Given this list of marker genes ATPAF2, CPSF3 (cleavage and polyadenylation specific factor 3), FRRS1L, EIF2AK1, PEX10, RNU4-2, SYNE1, CYB5A, POMGNT1, SCYL1, CLP1, NSD1, AQP4, MED23, CCDC88C, PSAP, CTNNB1, PTPN23, HECTD4, SAMHD1, YIF1B, H3-3A, FBXO7, GJA1, RNASEH2A, FKBP6, ERCC1, TMTC3, DAO, SLC16A2, MARS1, STN1, MPLKIP, SPTBN2, UNC80, SUCLA2, KCNB1, ARF1, COL4A2, PEX6, MYO5A, TSEN15, IFT56, LIAS, ATL1, IBA57, ERCC8, GAS1, PEX2, ASNS, EIF2S3, GTF2H5, TSEN2, AFG2A, HTRA1, TUBB3 (tubulin beta 3 class III), HMBS, DLD, MT-TF, EIF2B2, RPS6KA3, WASHC5, CTNNA2, PPFIBP1, EIF4A2, PRRT2, CLPB, UBTF, ZFYVE26, MED13L, GLE1, GFAP, SIX6, CRIPTO, ASCC3 (activating signal cointegrator 1 complex subunit 3), RLIM, GRIA4, SCN2A, GNAO1, ESAM, GRIN1, TEFM, LRRK2, NAGA (NCBI Gene Id 4668), NSRP1, REEP2, GLYCTK, CKAP2L, TPI1, PON2, SPR, REEP1, DARS2, NDUFA13, PCYT2, MT-ATP8, NEUROD2, MRPS22, RANBP2, PAFAH1B1, ZBTB11, DHPS, SATB1, SLC30A10, WDR45B, PRNP, ERCC2, ATP13A2, GBA2, MCCC2, TAF15 (NCBI Gene Id 8148), SDCCAG8, STAG2, TRAK1, YWHAG, IFT172, MRAP, WARS2, ERCC4, KIF1C, BBS7, RAB18, SDHD, ANKLE2, ATP1A2, PFN1, FOXH1, WLS, CAMLG, DNMT1, GRM7, PEX14, PNP, AASS, KCNJ6, VPS41, HIKESHI (heat shock protein nuclear import factor hikeshi), GBA1, LINGO1, ATXN7, NTRK2, GAMT, ABHD12, KLC2, DNAJC30, SLC39A14, SCYL2, GSX2, GABRA5, GAN, RAB3GAP2, ATXN2, AP4S1, MATR3, GLB1, PLAA, COL4A1, XPA, ATP7A, MED17, ISCA2, GM2A, TIMM50, ALS2, MINPP1, KCNA2, KDM5C, GJB1, GLRA1, NODAL, RERE, RAB3GAP1, NCF1, SCN4A, VAPB, ATP6V1E1, AP4B1, DPH5, SPAST, LIPT1, AARS2, STXBP1, ATP6V1A, NHLRC1, MED27 (mediator complex subunit 27), AP4E1, SUZ12, ATXN8OS, PLAAT3, MORC2, PNKP, DDHD1 (NCBI Gene Id 80821), OPHN1 (oligophrenin 1), TFG, TMEM63C, PRPS1, SHH, UGDH (NCBI Gene Id 7358), ATP5F1D, LONP1, COQ5, PHGDH, CEP19, PNPLA6, AMACR, WDR45, RUSC2, HSD17B10, EDNRB (endothelin receptor type B), EIF4H, SPTBN1, PON3, BAZ1B, ERBB4, PEX26, DSTYK, COG2, EML1, SDHB, MT-ND4, KIF2A, SV2A, SLC12A6, PRKN (parkin RBR E3 ubiquitin protein ligase), POLR1A, FOXP1, PARK7, STUB1, FBXO28, GTPBP2, MT-ND3, PRPH, TTI1, TREX1 (NCBI Gene Id 82474), MFSD2A, PIGA, BBS9, PPT1, MOCS2, GCDH, ENSG00000288330, RNASEH2B, TRMT10A, RFT1 (NCBI Gene Id 91869), CYP27A1, LYRM7, TSEN34, BBIP1, HEXB, ELOVL4, MTPAP, DDB2, TRAPPC4, CLTC, MARS2, POLR1C, KIF5C, KANK1, SCN3A, GAD1, ERLIN1, ZSWIM6, AARS1, KCNA4, NDUFV2, RFXANK, CACNA1B, SPG7, SYNGAP1, RAB11B, KIF11, HCN1, ATP5F1A, GRIN2D, NDUFA2, ACAT1, GFM1, EPM2A, MED12 (mediator complex subunit 12), NAA10, HEPACAM, UBE4A, ZIC2, NR2F1, ATP6V0A2, MECR, NDE1, KCNC3, RNASET2, TDP1, SLC6A8, ATN1, ECHS1, GTF2E2, CYFIP2, KPNA3, PSEN1, TBP, GLRX5, SCLT1, EZH2, CEP85L, TRAPPC12, SLC32A1, CDC40, DRG1, UBAP1, TBCD, SLC25A22, NUS1, ANXA11, NEFH, RNF170, ABCC8, ATXN10, PSMC1, PEX16, WDPCP, GABRB2, WARS1, DHCR24, ABCD1, SLC12A2, LMNB1, TNR, NOTCH3 (notch receptor 3), MT-TW, SNORD118, ABCA12, NEFL, AFG3L2, PEX1, NALCN, CHMP1A, INPP5K, XPC, AFG2B, TCF20, ACBD6, ACTL6B, VRK1, NFU1, SLC1A4, GJC2, DNM1L, TMEM222, BUD23, CCT5, CEP290, RTTN, INTS8, GRM1, PI4K2A, NDUFV1, PQBP1, RAD50, MTHFR, MAG, STX1A, CPT1C, CLCN4, FTH1, TUBGCP2, DYM (NCBI Gene Id 54808), MTO1, ASPA, SPG11, DCTN1, ODC1, PRDM8, SCAPER, PEX12, ADAR, EXTL3, PRDM13, OSTM1, OSGEP, TIMM8A, KIF1A, FOXG1, DTYMK, ELN, NACC1, WDR4, GRIN2B, NADK2, REPS1, ZNF335, DPM1, ARSI, CIT (NCBI Gene Id 11113), ATAD1, ENTPD1, ADGRG1, CACNA1D, DCX, TCEAL1, TMEM270, MCOLN1, AMFR, NKX6-2, SDHA, RNU7-1, SETX, PTCH1, TPK1, FLNA, MKKS, NUBPL, POLR3B, OTUD6B, CAMK2B, GOT2, KCNT1, OPA1, ERCC3, L1CAM, SHQ1, LIPT2, CTC1, UBQLN2 (NCBI Gene Id 29978), EXOSC5, BCS1L, GCH1 (NCBI Gene Id 93984), MCCC1, NPC1, TANGO2, PNPT1, PIGN, KARS1, GLI2, DISP1, LZTFL1, SQSTM1, SPTAN1, IFT27, TRMT5, SOX2, ADAT3, ATP6AP2, ATXN1, CNKSR2, PIGP, CYB5R3, HACE1, PARS2, ARSA, SPG21, CACNA1G (calcium voltage-gated channel subunit alpha1 G), POLG, SZT2, C2orf69, MICOS13, AUTS2, TMX2, CRLF1, ZNF668 (zinc finger protein 668), MSL3, BEAN1, KMT2B, FDX2 (NCBI Gene Id 2143), SNCA, PPP3CA, DDX3X, RNASEH2C, TELO2, LIMK1, GATAD2B, MAN2B1, GDAP2, PGAP1, NTNG2, PEX13, TSPOAP1, GFM2, KRAS, NPHP1, MT-ND1, TXN2, TBCE, PPIL1 (peptidylprolyl isomerase like 1), NIPA1, STAMBP, SRD5A3, LYST, TMEM67 (NCBI Gene Id 91147), COPB1, GRIA3, MT-ND6 (mitochondrially encoded NADH:ubiquinone oxidoreductase core subunit 6), ABHD16A, IREB2, COX15, BBS10, NEXMIF, TYROBP, AFF3, ANK3, SLC19A3, MOCS1, WDR48, MFN2, CFAP418, ATP5MK, ISCA1, AGTPBP1, SETBP1, RNU4ATAC, SMPD1, RFC2, TECPR2, IFT74, UNC13A, CLIC2, HPDL (NCBI Gene Id 84842), PLP1, FTL, HTRA2, CNOT1, PCDH12, ARG1, ADARB1, VPS50, AIFM1, AMPD2, CAMK2A, GBE1, EXOSC8, WWOX, MRPS34, TUBB4A, PEX3, BICD2, TCTN2, CELF2, FGF8, IRF2BPL, NAXD, CASP2, GEMIN4, KY, APC2, MED25, ALG11, PODXL, TAF4, BCKDHB, SELENOI, CSF1R, SACS, PAX3, TAF1, CDKL5, UBA5, BBS5, ACTB, SLC18A2, BCAS3, GABRA2, MT-ND2, FAR1, TTC19, ERCC6, TREM2, PON1, COQ4, MT-TV, GABBR2, NTNG1, PEX5, SNX14, KATNB1, SERAC1, FUS, CACNA1C, DLL1, CNTNAP2, LAGE3 (L antigen family member 3), SIK1 (NCBI Gene Id 54018), SVBP, TARS1, GUF1, LETM1 (leucine zipper and EF-hand containing transmembrane protein 1), CFAP410, NUP62, ARL6, MAPT, VPS4A, SUMF1, SCN1A, GPAA1, AUH, PEX7, HSPD1, MT-TL1, TP53RK, FIG4 (FIG4 phosphoinositide 5-phosphatase), CHP1, ARL6IP1, ZNF592, COASY, DNAJC19, MCEE, DMXL2, VCP, SDHAF1, AP1G1, SIX3, TBK1, UFM1, CARS1, GTF2IRD2, EPRS1, HSD17B4, ELOVL1, VPS13D, KCNC2, SLC6A5, BCL11B, IFIH1, SYNJ1, FZR1, ARX, RNF13, HMGCL, RPIA, PLA2G6, ATP5F1E, PYCR2, RALGAPA1, TRIT1, GPHN, GRIK2, SIGMAR1, CACNA1E (NCBI Gene Id 777), FARS2, IDUA, ZC4H2, ASPM, BTD, AGA (aspartylglucosaminidase), TAF8, ATXN3, ZEB2, TARDBP, COX8A, L2HGDH, TRIM8, CLIP2, PMPCA, GPRC5B, SLC4A10, BBS12, ATP2B3, SEC31A, EIF2B1, CARS2, BBS2, ATM, FA2H, TBC1D20, NDUFC2, C19orf12, NUP214, SRPX2, POLR3GL, AHDC1, JAM3, EXOC8, KCNA1, SNAPC4, OCLN, NEK1, ATP6V0A1, ROGDI, PPARGC1A, PLCB4, SOD1, HID1, NDUFA4, PDHX, SIL1, ADD3, PNPLA8, MRM2, SLC38A3, HTT, B4GALNT1, EARS2, PTRHD1, KCNQ2, SLC17A5, NDUFAF5, IARS1, ERLIN2, WDR26, TGIF1, DNAJC6, NDUFA8, FXN, PPP1R15B, TTC8, VAMP1 (vesicle associated membrane protein 1), FBLN1, MRE11, SON, TACO1, PIGU, POLA1, DYNC1I2, VPS53, SPTLC1, VPS37D, CHMP2B, COA8, CDK19, ANG, SLC25A12, MT-TP, PANK2, UFC1, MT-TI, PLCH1, DNM1, AP3B2 (NCBI Gene Id 8120), ADSL, DENND5A, SLITRK2, BBS4, EBF3, ZFR, RBMX, GALC (galactosylceramidase), KIF5A, AP1S2, SPTSSA, DALRD3, THOC2, GLT8D1, PIGQ, SMC1A, CNPY3, WDR73, PRUNE1 (NCBI Gene Id 91961), DBT, RNF220, USP8, VPS13C, NUP54, CLCN3, EXOSC9, PET100, ITPR1, TSEN54, CTSD, FGF12, PHACTR1, LRPPRC, HLA-DRB1, PSAT1 (phosphoserine aminotransferase 1), VPS37A, GMPPA, VPS11, SATB2, NSUN2, PLCB1, POLR3A, GTF2I, ATP5MC3, MTFMT, HPRT1, MTHFS, NDUFA6, COPB2, APC, LSM11, EXOSC3, HLA-DQB1, TUBG1, CTCF, LMBRD2, ASAH1, TGFB1, ALG9, DHDDS, HNRNPA1, TBL2, NDUFAF4, CHCHD10, CYP2U1, GRIA2, MKS1 (NCBI Gene Id 54903), ARPC5, SLC25A15, OPA3, MECP2, LAMB1 (NCBI Gene Id 3912), GPT2, RTN2, SOX4, HUWE1, KIDINS220, PACS2, FRMPD4, PCLO, EXOC2, CDON, SLC25A46, SLC1A2, CACNA1A, STIL, PTS, ATP1A3, CCNF, GABRG2, BOLA3, SLC5A6, SCN8A, MFF, ATAD3A, GSS, WDR62, TOE1, PEX11B, FUCA1, LMX1B, EIF2AK2, TUBA1A, BCOR, MTRFR, PEX19, GLRB, MTR, SOX10, RARS2, CASK, DARS1, DDHD2, MT-TK, INPP5E, CLN8 (CLN8 transmembrane ER and ERGIC protein), ACER3, COG3, ITM2B, NPC2, RAP1GDS1, IKBKG, METTL5, TBC1D23, CRELD1, FLRT1, SLC25A10, TRIM32, DEGS1, RARS1, ARNT2, RAB27A, EEF1A2, TPRKB, MT-ATP6, FGFR1, POU3F3, NARS2, ADAM22, MLC1, ERCC5, BSCL2, RETREG1, SLC35A2, CNTNAP1, METTL27, SCN1B, APOE, ALDH18A1, MACF1, SLC13A5, SHMT2, SLC2A1, PMPCB, CYP7B1, TAF2, MT-ND5, TUFM (Tu translation elongation factor, mitochondrial), NDUFS4, SEPSECS, NECAP1, AP5Z1, FDXR, ALDH3A2, NT5C2, WASHC4, EIF2B4, UCHL1, UGP2, GTF2IRD1, CNP, PINK1, SPART (NCBI Gene Id 23111), BBS1, PI4KA, TTR, MAPK8IP3, SLC33A1, COLGALT1, DYNC1H1, VWA3B, AP4M1, ELP2, ACP5, H4C5, ATRX, AIMP1, FRMD5, RNF113A, FCSK, CACNA2D1, OPTN, NEU1, CAPN1, B4GAT1, ALG3, NOVA2, here is a description of the gene set: Spasticity studied in species Homo sapiens Human Gene Set: HP_SPASTICITY A motor disorder characterized by a velocity-dependent increase in tonic stretch reflexes with increased muscle tone, exaggerated (hyperexcitable) tendon reflexes.